Given this list of marker genes AGA, COL11A1, COL10A1, SMAD3, COL12A1, MRAS, IL10, PIGY, PRPS1, FAT4, AMER1, AP1S3, NDUFAF6, DLL1, WDR73, MEN1, TLK2, ERLIN1, KIF1A, RAD51, MACF1, SLC6A5, CHN1, ATL3, EP300, CCR1, DPAGT1 (dolichyl-phosphate N-acetylglucosaminephosphotransferase 1), C12orf57, HS6ST1, CHMP1A (charged multivesicular body protein 1A), NLRP12, PAX3, TUBB3, AEBP1, COG5, ADAR, SPAST (NCBI Gene Id 6683), NGLY1, ARSL, KIAA0586, TBX2, TOM1, ALPL, POU3F4, LIMK1, RUNX2, NUP133, COL3A1, KCNJ1, ATP5F1D (NCBI Gene Id 513), IFNGR1, GTF2H5, EPCAM, THOC2, TNFSF4, SEC61A1, ZSWIM6, LMX1B, PIK3C2A, MEGF10, GNPNAT1, TP63, CHRND, SPP1, MAP3K20, CDON, PUF60, CANT1, MAF, ATP6AP2, SPTBN2 (spectrin beta, non-erythrocytic 2), CTBP1, MAGEL2, IL6ST, DDR2, GLRB, PHGDH, DOK7, FGB, TTN, IGHM, NIPA1, NONO, IFITM5 (NCBI Gene Id 387733), SLC5A7, KMT2B, SCYL2, BAZ1B, FGF9, DDB2, CHST3, SMO, NAE1, BTNL2, RNASEH2A, CRIPTO, SLC39A8, ATAD1, GPC3, SF3B4, ZNF699, SERPINE1, PLEKHG5, MFN2, COL6A2, PI4KA, B4GALT7, RPL13, KIF22, LONP1 (lon peptidase 1, mitochondrial), PTEN, SPTLC2, TRPV4, IGHMBP2, VWF, GFM2, CLCN5, H4C9, FGD1, NFU1, MAP2K1 (mitogen-activated protein kinase kinase 1), ALAD, EIF2AK3, KRT14, OSTM1, CTC1, TNXB, MYH8, WDR11, FCGR3B, SLC35A3, RAB3GAP2, RNU12, ERMARD, PSTPIP1, NT5C2, GPKOW, UFC1, SLC39A7, TBX3, TRAPPC12, GCM2, UGP2, FBN1, LUZP1, MVK, ESCO2, SPRTN, TGDS, COLEC11, NEDD4L, TIMM8A, SPTLC1, LAMB2, PTDSS1, C18orf32, LGI4, CADM3, RB1, GTF2E2, PSENEN, ARNT2, F11, GAS1, ASH1L, CLIP2, MCTP2, BPTF, NRCAM, SPTB, BICD2, HERC2, RBM8A, MBTPS1, KIF14, ZEB2, FHL1, CYP3A4, CEP120, PTCH2, LAGE3, TMEM222, MYL1, F7, TAF6, IKBKG, LETM1, B3GAT3, RERE, HSPB1, NPR2, UFD1, FBLN1, CHST14, PDCD1, CHRM3, HLA-DPB1, ADGRV1, HK1, ASAH1, TMEM70, POLR3B, ANAPC1, APC, SIGMAR1, IRF5, ABCC9, WASF1, ZPR1, GABRG2, JAG2, RNASEH2C, HLA-DPA1, SLC25A1, TBL2, RTN2, DHODH, AP2S1, OPA3, WBP11, ZIC2, TELO2 (NCBI Gene Id 9894), CPT2, HRAS, UBE4B (NCBI Gene Id 10277), SAMD9L, ASCC3, TCF3, DPYSL5, TGFB2, ADGRG1, NEB, IDH1, ORC6, MYD88, SLC12A3, TMCO1, SOS2, SYK, MAP3K7, INF2, CDH3 (cadherin 3), HFE, RNU4ATAC, GORAB, SCARB2, WNT7A, SPTAN1, ERAP1, DNAJC30, AUTS2, C4A, DHX16, CCN2 (cellular communication network factor 2), IGLL1, TNFSF11, VAC14 (VAC14 component of PIKFYVE complex), FANCC, SLC40A1, GNA11, MYL2, COL9A2, SLC34A2, ANKLE2, ITGB4, FUZ, SYNE2, BUD23, FLI1, LAMB3, KIAA0319L, PRMT7, CENPJ, MYBPC1, RNF113A, CEP85L (centrosomal protein 85 like, NCBI Gene Id 387119), PRDM16, NALCN, DONSON, ZIC1, MPLKIP, HIRA, SLC29A3, ABCD1 (NCBI Gene Id 215), DPM1, MAP1B, FANCL, TCF12, HLA-B (major histocompatibility complex, class I, B), NTN1 (NCBI Gene Id 9423), NUP107 (NCBI Gene Id 57122), ITCH, POLRMT, CLCNKB, SEC31A, FBXL3, NOP10, RREB1, NFKBIL1, ATP6V0A2, ERCC3 (NCBI Gene Id 2071), KDM5B, GPHN, NSD1, RAB18, ALG12, ABCC6, BLNK, MECOM (MDS1 and EVI1 complex locus), SLC18A3, HINT1, ACTA1, COG4, GJA1, MLX, SIX1, MYO18B (NCBI Gene Id 84700), RAD21, SPRED2, DNASE1, MAD2L2, ITGAM, TDO2, HPGD, PEX2, PITX1, RFX5, CAMK2A, ZIC3, CAV1, CYP27A1, LSM11 (LSM11, U7 small nuclear RNA associated), MUSK, PLAU, LMOD3, DNASE2, SMAD6, PKDCC, PEPD, HJV (NCBI Gene Id 9974), THSD4, DVL1, ATP6V1E1, PTPN22, C1R, RFC2, PLOD1, PCNT, TMTC3, GNB2, HNRNPA2B1, SMARCAL1, VAMP1, PSAP, IL12A, PIGL, MYOT, SMARCAD1, MEFV, IL23R, PTPN6, MAB21L2, MECP2, ADA2, RSPO2, ERLIN2, CNTNAP1, EIF4H, TMEM218, CPLX1, SLX4, ASPN, MIA3, ARID1B, SLC2A10, PDGFRB, DCHS1, RETREG1, CD247, MUC1, B3GLCT, LARS2, MTHFD1, MAN2C1, ADRA2A, CYP27B1, EVC, GLB1, AIP, HTT, TNNT3, CTNS, COL1A2, ZDHHC9, STUB1, MBTPS2, ERGIC1, SOX2, EVC2, WDR4, ANO10, FRZB, SV2A, SYNE1, EXOSC3 (exosome component 3), LRRC8A, CYP7B1, ERCC6, COL5A1 (collagen type V alpha 1 chain), CAPN1, SDHA, GBA1, GNE, SHOC2, IRAK4, RAB3GAP1, RAC3, FGG, UBE3B, SLC12A2, COQ4, ELN (NCBI Gene Id 2006), RAD51C, F8, TBC1D2B, TCEAL1, KRT1, SUFU, CCDC47, EXT1, SERPINF2, PSMD12, BGN, SLC4A1, ARVCF, MASP1, NRAS, HOXD10, ASXL3, SMAD4, ATP6V1A, PLAAT3, LRBA, SLC35D1, GMPPB, HPRT1, TP53, TNFRSF1A, FANCI, GNB1, TRIM8, ANKH (ANKH inorganic pyrophosphate transport regulator), RIT1, KY, HCN1 (NCBI Gene Id 609), HS2ST1, TMEM270, SLC52A3, POLR3GL, IRAK1, POLR1D, CCDC88C, PLOD3, SPARC, IGHG1, FA2H, KIAA0753, SDHB, SIL1, VANGL1, TRPS1, CLCN3 (chloride voltage-gated channel 3), PQBP1, SELENOI, ARFGEF2, STAG2, LMNB2, COL5A2, AP4S1, KIDINS220, SNORD115-1, CCR6, HOXA13, XPC, IL1RN, RYR3, SNAP25, COMT, IRX5, ATL1, KCNAB2, CHAT, FZD2, AGRN, ADAMTS2, CTCF, HES7, IL12A-AS1, SLC37A4, HAMP, UROS, STIL, PDPN, MYH14, TFR2, BMP2, ACVR1, CUL7, KDM6A, IL12B, CBFB, TNIP1, MCOLN1, PWAR1, MAPK8IP3, TREX1, PSAT1, FGFR2, GNPAT, CSPP1, GTF2I, ARPC4, FBXW11, EBF3, BRCA1, LRP1, HNF1B, FKBP6, SOX5 (NCBI Gene Id 6660), FANCA (FA complementation group A), GLRA1 (NCBI Gene Id 2741), SAMHD1, TPM2, ABCG8, SMARCA2, AIFM1, MATN3 (NCBI Gene Id 4148, matrilin 3), TF, ARL6IP1, ECEL1, NIPBL (NCBI Gene Id 25836), HSPG2, IFT172, RTTN, HLA-C, LRP6, NADSYN1, FLVCR2, UCHL1, DSTYK, PEX5, SVIL, ALG3, C19orf12, OFD1, SLC34A3 (solute carrier family 34 member 3), TBX1, XRCC2, YRDC, CIITA, GBA2, TWIST1, TNFAIP3, COLQ, P4HTM, CHRNB1, CYP2R1 (NCBI Gene Id 79445), ELF4, DHCR24, GTF2IRD1, CD40LG, GDF6, OCRL, PTCH1, DYSF, PYROXD1, IRF6, OCA2, GCDH, ATRX, UMOD, ERCC4, NLRP1, CRKL, SALL1, SMC3, FCGR2A, GPX4, ETS1, SPART, PMP22, SPI1, KMT2D, KLHL41, LMAN1, GLA, IRF4, TNFRSF11B, WNT5A, SIN3A, SDHD, AHDC1, RNU7-1, SLC39A13, PRRT2, EBP, CYP19A1, DYRK1A, DCLRE1C, ERCC8, GP1BB, ALPK3, B3GALT6, DNAJB11, SNORD116-1, EPB42, NOG (noggin), BICRA, LBR, SLC6A9, SMC1A, CHUK, FKBP10, SAT1, RNF168, NR4A2, SOS1, AFF3, NDUFS8, VPS13A, NHP2, VARS1, NTRK1, GARS1, SHARPIN, AP4M1, VPS37D, SLCO2A1, CFI (complement factor I), TIMM22 (translocase of inner mitochondrial membrane 22), GALC, BANF1, WRN, UBR7, PRKCZ, CD244, FILIP1, FLNC, DYNC2I1, MORC2, SLC35B2, FANCG, ADSS1, SPEN, AARS1, TTI1, GNS, FOXP3, DLK1, GSC, BCOR, ELP1, GNPTG, F5, HDAC8, EFEMP2, COPA, TP53RK, SLC22A4, PTH1R, MAP2K2, GJB6, YY1, WDR62, IGF2 (insulin like growth factor 2), SCN1B (NCBI Gene Id 6324), F13A1 (coagulation factor XIII A chain), PRKACB, IDS, MEGF8, DNASE1L3, CASP10, NSD2, KAT6B, STAT3, EFL1, ITGA6, ACTG1, NOTCH2, SELENON, ERCC5, BCR, FIG4, EMILIN1, SLC39A14, SOD1, COL6A3, SHOX, PIK3R1, MAFB (NCBI Gene Id 9935), SLC10A7, CTLA4, NODAL, WAS (NCBI Gene Id 7454), FLNB, RIGI, UNC80, F13B, XIAP (X-linked inhibitor of apoptosis), SATB2, BRCA2, GFPT1, ORC4, ALX3, FGFRL1, BMP1, MED25, PRKAR1A (protein kinase cAMP-dependent type I regulatory subunit alpha), PHLDB1, RYR1, ASXL2, DNAJC21, KLC2, GPC6, STAG1, FANCE (FA complementation group E), COL9A3, PTPN2, SPEG, POMT1, HACD1, GGCX, CD79A, TAF4, LMBR1, ZMYM3, G6PC1, STT3A, GNAS, DMP1, CRLF1, UBE2T, CFL2, LMNA, PXK, NXN, OBSL1, TBX4 (NCBI Gene Id 9496), CLDN16, ADNP, PRKACA, NFATC2, KRT5, MET, CDT1, NOD2, GET4, PEX6, STAT4, CDH11, MEOX1, NKX3-2, SIX6, TFE3, FBXO28, PDE4D, SRY, F2, SLC16A2, OTULIN, FAS, C4B, ACTG2, NFIX, GLI1, PYCR1, IFT52, FGFR1, RAG1, CHD7, GPC4, CHD4, RIPPLY2, LFNG, COL9A1, GEMIN4, DCC, PALB2, VPS13B, ADAMTS3 (NCBI Gene Id 9508), SRD5A3, TBCD, FXYD2, TBX22, DOCK11, PAFAH1B1, CLCN7, UBAP2L, NEPRO, ZNF469, UBE3A, SBDS, KCNK9, CRELD1, TBX15, TFAP2B, RNASEH2B, PIEZO1, AKT1, FGF13, RAB33B, CHST11, MKRN3, SCN2A (NCBI Gene Id 94312), DAG1 (NCBI Gene Id 1605), PAM16, IL2RA, METTL27, NANS (NCBI Gene Id 54187), RAPSN, MAN2B1, WDR19, ANK1, PIGV, KMT2A, LYSET, FLT4, MMP23B, GNPTAB, EZH2, FANCB, ALDH18A1, FBLN5, PPP2R5D, MAPK1, UPF3B, ENPP1, COL6A1, RPS15A, PRTN3, UBE2A, SRCAP, FN1, IHH, PYCR2, MKKS, NUP88, SERPINF1, DKK1, EMG1, CHSY1, PIGT, BTK, LAMA2, ADAT3, NAA60, MYO9A, FERMT1, BPNT2, HNRNPH1, COL11A2, SCO2, GLE1, CR2, FDFT1, GJC2, GLDN, HYAL1, BAG3, DMD, ARF1, MACROH2A1, IL6, PLA2G6, TRIP11, GRB10, NOTCH3, AP4E1 (adaptor related protein complex 4 subunit epsilon 1, NCBI Gene Id 23431), CDC6, CENPT, PSMB4, MYL11, TNNT1 (troponin T1, slow skeletal type), UBAC2, BRIP1, ITGA7, FGF10, RIPK4, TONSL, POLR1A, COX11, IMPDH2, GJB2, ZMPSTE24, INPPL1, ORC1, ABCG5, FUT8, ASXL1, FASLG, SHH, LTBP1, ACAN (NCBI Gene Id 404712), WDR35, PNPT1, SPTA1, RPL10, CCDC22, XYLT1, COL7A1, FGFR3 (fibroblast growth factor receptor 3), POGLUT1, KIF5A, MTX2, FLVCR1, BRF1, PPP1CB, ARSK, PORCN, SCN9A, PUS3, UBA1, SYT2, IARS2, C1S, SPTBN1, LARGE1, CYP26B1, TRIM2, SMG9, BLK, TPRKB, TBC1D7, CDC45, PEX1, CCBE1, UFSP2, SNRPB, GAN, POMT2, APOE, BRD4, ATR, GCH1, IPO8, GDF3, DYNC2H1, PERCC1, YWHAE, CARS1, F9, FANCF, HNRNPA1, MLXIPL, CHRNG, GCSH, RINT1, TBX6, KANSL1, SCARF2, GTF2IRD2, PPIB, IDH2, ATP7A, FANCM, COL27A1, TLR7, TOR1AIP1, AP4B1, PIK3R2, REEP1, ERCC1, ADGRG6, RAB23, NGF, EXOC6B, ALG14, LRP4, HEPHL1, CCN6, KRT16 (keratin 16), HGD, MADD, MYOD1, SLC12A1, STX1A (NCBI Gene Id 6804), PEX16, SF3B2, POLR3A, KLHL9, ROR2, HLA-DRB1, DYM, IDUA, ZNF687, XPA, SDHAF1, MKS1, NIN, C2orf69, CLTCL1, TWIST2, BMP4, PIK3CD, COLEC10, GMNN, SUZ12, RSPRY1, PIEZO2, KRAS, CBS, COMP, CUL4B (cullin 4B), LMBRD2, RTL1, ZC4H2, TUBA1A, MMP14, CAPN3, WIPF1, FCGR2B, DKC1, PLEC, POP1, SOX9, SPG11, EFNB1, RPL26, ARSB, LACC1, GON7, ACTB, KIF7, DNAL4, SLC1A4, H3-3B, NAA10, POFUT1, EXTL3, SIK3, GALNS, TLR4, ANTXR2, MARS1, PRG4, HEATR3, BRAF, ANKRD11, FBN2, BMP6, WNK1, SHROOM4, THBS2, L1CAM, MPZ, IGKC, PHEX, FGF16, FKTN, RAG2 (recombination activating 2), TOR1A, VDR, CD96, RRAS, TFAP2A, TARS1 (NCBI Gene Id 94887), COL25A1, THRA, ALG2, SH3PXD2B, FGA, NDRG1, HBB (NCBI Gene Id 3043), DHCR7, WNT4, ORAI1, LEMD3, EXT2, BMPER, STX5, DYNLT2B, KNSTRN, DYNC2LI1, BRPF1, CBL, JARID2, DLG5, SGCA, FKRP, SMOC1, ALG9, KPNA3 (NCBI Gene Id 3839), OSGEP, FOXH1, ANKRD55 (NCBI Gene Id 79722), TMEM43, SLC35A2, TGFB1, FBXO11, ERCC2, C1QB (complement C1q B chain), BMPR1B, IL36RN, RECQL4, GDF5, NSDHL, USP9X, RFWD3 (NCBI Gene Id 55159), LAMA5, CNTN1, GUSB, RAF1, POR, IFIH1, TBR1, MED12, MMP13, GABRD, NLRP3, GDAP1, SCN4A, ANGPT2, MMP2, CSGALNACT1, SCN1A, IGHG2, KAT6A, AFF4, ECE1, GABRA1, CASZ1 (castor zinc finger 1), JMJD1C, PSMB8, SLC26A2, SERPINH1, COL13A1, APC2, NCF1, MEG3, GZF1, PWRN1, JAZF1, ALX1, CREBBP, DLL3, PRKG2, SEC24C, SETD2, STXBP1, CHEK2, VCP, SETBP1, TGFBR2 (transforming growth factor beta receptor 2), FLNA, HDAC4, COG1, PIGA, ANO5, FGF8, LPIN2, RASA2 (NCBI Gene Id 5922), UBA2, COX8A, TGIF1, GLI2 (GLI family zinc finger 2), PIK3CA, BIN1, SFRP4, DVL3, VPS33A (VPS33A core subunit of CORVET and HOPS complexes), EYA1, SIX3, TGFBR1, SKI, RMRP, TMEM67, TBX5, MCFD2, MESP2, RPGRIP1L, PRR12, PFKM, KDM5C, IL2RB, FANCD2, COL2A1, TBK1, IFT57, ADAMTS15, CHRNA1, SLC25A46, GPR101, LTBP3, PDXK, P4HA2, NPAP1, PTRH2, SPTBN4, TPM3, PLCH1, TGFB3, ZNF407, WNK3, CCDC8, BANK1, MMP9, CTDP1, KIF21A, KLRC4, SSR4, EIF4A3, DISP1, AP3B1, ATP7B, CLCF1, LIFR, UBE2L3, GLI3, ADAMTSL2, KRT9, GRIA3, CD79B, MIF, F10, RRAS2, NF1, ZBTB20, CDC73, COL1A1, HOXA11, HACE1, TRAPPC2, ACP5, PCDH19, DNMT3A, SLC4A10, ASPH, KIF1C, SALL4, PRKCD, HOXD13, EMD, LZTR1, DDRGK1, LYN, TCTN3, TNNI2, PTPN11, STX1B, IFT56, MYH3, ZFX, DSE, PPP2R3C (NCBI Gene Id 55012), BHLHA9, CRTAP, COG8, PLOD2, ERI1, SMAD2, NEFL, GHR, here is a description of the gene set: species: Homo sapiens Human Gene Set: HP_ABNORMAL_JOINT_MORPHOLOGY Abnormal joint morphology An abnormal structure or form of the joints, i.e., one or more of the articulations where two bones join.